The following is a description of a gene set: Human Gene Set: GOBP_CENTRAL_NERVOUS_SYSTEM_MYELIN_FORMATION The process in which the wraps of cell membrane that constitute myelin are laid down around an axon by an oligodendrocyte in the central nervous system. studied in species Homo sapiens, and this is the list of marker genes: TENM4, ABCA2, MAG, ERCC2, MIOS, CNTN1